Given this list of marker genes CAVIN1, PAX5, ZNF22, MLLT3, FOXB1, NDN, NAB2, TFCP2L1, ZFP14, NR1H3, EGR1, HOXA4, SMAD1, TEAD1, AR, PAX9, JUN, ARNT2, DLX5, FOS, ARX, HR, HIC1, TSC22D1, TEAD2, BACH1, PBX3, HAND2, SPIB, HDAC5, NOTCH1, ZFP37, KLF6, KLF9, SATB1, ESR1 (estrogen receptor 1), GATA6, here is a description of the gene set: studied in species Mus musculus Human Gene Set: RIZ_ERYTHROID_DIFFERENTIATION_12HR Selected genes down-regulated in the TLX1 Tet On iEBHX15-4 cells (pro-erythroblasts) at 12 h time point. Aberrant expression of the human homeobox-containing proto-oncogene TLX1/HOX11 inhibits hematopoietic differentiation programs in a number of murine model systems. Here, we report the establishment of a murine erythroid progenitor cell line, iEBHX1S-4, developmentally arrested by regulatable TLX1 expression. Extinction of TLX1 expression released the iEBHX1S-4 differentiation block, allowing erythropoietin-dependent acquisition of erythroid markers and hemoglobin synthesis. Coordinated activation of erythroid transcriptional networks integrated by the acetyltransferase co-activator CREB-binding protein (CBP) was suggested by bioinformatic analysis of the upstream regulatory regions of several conditionally induced iEBHX1S-4 gene sets. In accord with this notion, CBP-associated acetylation of GATA-1, an essential regulator of erythroid differentiation, increased concomitantly with TLX1 downregulation. Coimmunoprecipitation experiments and glutathione-S-transferase pull-down assays revealed that TLX1 directly binds to CBP, and confocal laser microscopy demonstrated that the two proteins partially colocalize at intranuclear sites in iEBHX1S-4 cells. Notably, the distribution of CBP in conditionally blocked iEBHX1S-4 cells partially overlapped with chromatin marked by a repressive histone methylation pattern, and downregulation of TLX1 coincided with exit of CBP from these heterochromatic regions. Thus, we propose that TLX1-mediated differentiation arrest may be achieved in part through a mechanism that involves redirection of CBP and/or its sequestration in repressive chromatin domains. from publication Riz I, Akimov SS, Eaker SS, Baxter KK, Lee HJ, Mariño-Ramírez L, Landsman D, Hawley TS, Hawley RG (PMID 17213805)